The following is a description of a gene set: The process in which the anatomical structure of the cerebellar Purkinje cell layer is generated and organized. The Purkinje cell layer lies just underneath the molecular layer of the cerebellar cortex. It contains the neuronal cell bodies of the Purkinje cells that are arranged side by side in a single layer. Candelabrum interneurons are vertically oriented between the Purkinje cells. Purkinje neurons are inhibitory and provide the output of the cerebellar cortex through axons that project into the white matter. Extensive dendritic trees from the Purkinje cells extend upward in a single plane into the molecular layer where they synapse with parallel fibers of granule cells. Mouse Gene Set: GOBP_CEREBELLAR_PURKINJE_CELL_LAYER_MORPHOGENESIS species: Mus musculus, and this is the list of marker genes: Cend1, Atp2b2, Herc1, Sptbn2, Slc25a46 (NCBI Gene Id 67453), Atxn2, Lhx1, Rora, Ttll1, Whrn, Dll1, Agtpbp1, Kif14, Atp7a (NCBI Gene Id 51824), Foxp2, Gba1, Faim2, Ttc21b, Lhx5, Coq8b, Psap, Ldb1, Cntnap2, Cacna1a, Skor2